The following is a description of a gene set: Mouse Gene Set: ZAMORA_NOS2_TARGETS_DN Nitric oxide (NO) can modulate numerous genes directly; however, some genes may be modulated only in the presence of the inflammatory stimuli that increase the expression of the inducible nitric oxide synthase (iNOS). One method by which to examine changes in NO-mediated gene expression is to carry out a gene array analysis on NO-nai;ve cells. Herein, we report a gene array analysis on mRNA from iNOS-null (iNOS(-/-)) mouse hepatocytes harvested from mice exposed to NO by infection with an adenovirus expressing human iNOS (Ad-iNOS). Of the genes on this array, only approximately 200 were modulated either up or down by the increased iNOS activity according to our criteria for significance. Several clearly defined families of genes were modulated, including genes coding for proinflammatory transcription factors, cytokines, cytokine receptors, proteins associated with cell proliferation and cellular energetics, as well as proteins involved in apoptosis. Our results suggest that iNOS has a generally anti-inflammatory and anti-apoptotic role in hepatocytes but also acts to suppress proliferation and protein synthesis. The expression of iNOS results in increased expression of stress-related proteins, including heme oxygenase-1 (HO-1). We used HO-1 to confirm that a significant change identified by an analysis could be demonstrated as significant in cells and tissues. The elevation of HO-1 was confirmed at the protein level in hepatocytes in vitro. Furthermore, iNOS(-/-) mice experienced greatly increased liver injury subsequent to intestinal ischemia/reperfusion injury, associated with an inability to upregulate HO-1. This is the first study to address the global gene changes induced by iNOS in any cell type, and the findings presented herein may have clinical relevance for conditions such as septic or hemorrhagic shock in which hepatocytes, NO, and HO-1 play a crucial role. Down-regulated in hepatocytes upon expression of NOS2. studied in species Mus musculus from publication Zamora R, Vodovotz Y, Aulak KS, Kim PK, Kane JM 3rd, Alarcon L, Stuehr DJ, Billiar TR (PMID 12381414), and this is the list of marker genes: Eif3b, Vwf, Ssc4d, Hspb8, Sox17, Tspan4, Apob, Nfia, Sord, Serping1, Ifnar2, Ctsz, Rras, F12, Cd81, Tnni3, Cd36, Atp1a1, App, Pea15a, Vdac1, Lonp1, Ubc (NCBI Gene Id 77003), Atp6v0c, Cacnb3, Actb, Fabp1, Pcyt1a, Cd151, Hpn, Ddb1, Sars1, Eif5a, Scn1b, Capns1, Gclm (NCBI Gene Id 99692), Myh9, Prpsap1, Stard10, Eef1a1, Alox5ap, Galk1, Ripk1, Atp5f1d, Ywhaq (tyrosine 3-monooxygenase/tryptophan 5-monooxygenase activation protein theta), Man2a1, Eif2s2, Cyp7a1, Sox4, Cp, G3bp2, Eef2, Slc6a13, Hp, Dync1h1, Ftl1, Slc6a8, Gnb2, Map2k2, Rars1, Actn4, Eif4g3, Mgat1, Akr1c6, Myl2, Ppp1ca, Azgp1, Zfp36l1, Efs, Pdia4, Fkbp3, Fzd4 (frizzled class receptor 4), Serpinc1, Rabac1, Cfh, Fdx1, Ugt2b5, Ap1b1, Stat3, Jup, Ppp2r1a, Pdia3